The following is a description of a gene set: Any process that modulates the frequency, rate or extent of female gonad development. species: Homo sapiens Human Gene Set: GOBP_REGULATION_OF_FEMALE_GONAD_DEVELOPMENT, and this is the list of marker genes: RETN, NR5A1, ZFPM2 (zinc finger protein, FOG family member 2), INSR, WT1, GDF9, NUPR1